Given this list of marker genes CRK, FARP1, CRKL, TNFAIP6, MESD, DOK7, RAC1, LRP4, ZDHHC2, SSH1, FNTA, CD81, here is a description of the gene set: Human Gene Set: GOBP_POSITIVE_REGULATION_OF_RECEPTOR_CLUSTERING Any process that activates or increases the frequency, rate or extent of receptor clustering. studied in species Homo sapiens